Given this list of marker genes VGLL3, JUN, YEATS4, PTPRT, TSPAN31, TOP1, MDM2, TAB2, POU1F1, CDK4, APOA2, SRC, USF1, here is a description of the gene set: Ring chromosomes and/or giant marker chromosomes have been observed in a variety of human tumor types, but they are particularly common in a subgroup of mesenchymal tumors of low-grade or borderline malignancy. These rings and markers have been shown to contain amplified material predominantly from 12q13-15, but also sequences from other chromosomes. Such amplified sequences were mapped in detail by genome-wide array comparative genomic hybridization in ring-containing tumor samples from soft tissue (n = 15) and bone (n = 6), using tiling resolution microarrays, encompassing 32 433 bacterial artificial chromosome clones. The DNA copy number profiles revealed multiple amplification targets, in many cases highly discontinuous, leading to delineation of large numbers of very small amplicons. A total number of 356 (median size: 0.64 Mb) amplicons were seen in the soft tissue tumors and 90 (median size: 1.19 Mb) in the bone tumors. Notably, more than 40% of all amplicons in both soft tissue and bone tumors were mapped to chromosome 12, and at least one of the previously reported recurrent amplifications in 12q13.3-14.1 and 12q15.1, including SAS and CDK4, and MDM2, respectively, were present in 85% of the soft tissue tumors and in all of the bone tumors. Although chromosome 12 was the only chromosome displaying recurrent amplification in the bone tumors, the soft tissue tumors frequently showed recurrent amplicons mapping to other chromosomes, that is, 1p32, 1q23-24, 3p11-12, 6q24-25 and 20q11-12. Of particular interest, amplicons containing genes involved in the c-jun NH2-terminal kinase/mitogen-activated protein kinase pathway, that is, JUN in 1p32 and MAP3K7IP2 (TAB2) in 6q24-25, were found to be independently amplified in eight of 11 cases with 12q amplification, providing strong support for the notion that aberrant expression of this pathway is an important step in the dedifferentiation of liposarcomas. species: Homo sapiens from publication Heidenblad M, Hallor KH, Staaf J, Jönsson G, Borg A, Höglund M, Mertens F, Mandahl N (PMID 16732325) Genes from selected recurrently amplified regions in soft tissue tumors with supernumerary ring chromosomes. Human Gene Set: HEIDENBLAD_AMPLIFIED_IN_SOFT_TISSUE_CANCER